The following is a description of a gene set: studied in species Homo sapiens The process in which a relatively unspecialized cell acquires specialized structural and/or functional features of a somatotropin secreting cell. A somatotropin secreting cell is an acidophilic cell of the anterior pituitary that produces growth hormone, somatotropin. Human Gene Set: GOBP_SOMATOTROPIN_SECRETING_CELL_DIFFERENTIATION, and this is the list of marker genes: PROP1, PITX2 (paired like homeodomain 2), WNT4, GHRHR, LHX3